The following is a description of a gene set: from publication Yevshin I, Sharipov R, Kolmykov S, Kondrakhin Y, Kolpakov F (PMID 30445619) Genes containing one or more binding sites for (Taf10) in their promoter regions (TSS -1000,+100 bp) as identified by GTRD version 20.06 ChIP-seq harmonization. species: Mus musculus Mouse Gene Set: TAF10_TARGET_GENES, and this is the list of marker genes: Kmt2d, H2ac14-ps, 2700062C07Rik, Itga2b, Ngp, Trim80, Il21r, Sucnr1, Aoah, Fermt3 (fermitin family member 3), Itgb5, Mrpl44, 1700122E12Rik, Ski, Piezo1, Atg14, Madd, Ndufa5, Ankrd13a, Cdc123, Hs2st1, Ece2, Cebpz, Snord49a, Tchp, Ptgs2os2, Lig1, Taf11, Oit3, Rbm47, Ppp1r15b, Epb41l4aos, Alkbh2, Med6, Cfap126, Trappc3l, Zfp276, Mrpl22, Mirt1 (NCBI Gene Id 78096), Misfa, Gpld1, Trabd, Ncor1, Ppil1, Lss, Gbp11, Rbak, Klhl20, Cir1 (NCBI Gene Id 74817), Anp32e, Sgsm1, Fdps, Secisbp2, C920006O11Rik, Rab21, Dhodh, Mrpl39, Lyrm1, Trmo, Sec24a, Syne2, H2ac4 (H2A clustered histone 4), Tifab, Gpr107, Cd274, Hmga1, Osbpl6, Klhdc4, Gm13421, Taf13, Gclm, Dhx38, Vsir, 4930532M18Rik, Hoxa7, Abca13, Txnl1, Polr1f, Hepacam2, Rps12, Cenpw, Lsm8, Rpl18, Ubr4, Lrrc24, Tspan32, Brix1, Cep57l1, Slc39a14, Rin2, Mmp8 (matrix metallopeptidase 8), Psmg3, H2ac15, Ccng1, 1810024B03Rik, Rab11a, Gm15564, Polr1b, H2ac22, Ncbp2as2, Gm12279, H3c3, Isg20, Tm9sf4, Ctnnb1, Triobp, 2310010J17Rik, Dip2a, Fam43a, Gm8000, Naa25, Tm9sf1, Utp14b (UTP14B small subunit processome component), Nbeal2, Mapkapk3, Mrpl21, Plek, Polg2, Sla, Git2, Cd53, Pex1, Glrx3, Dus2, Gtf3c5, Psap, Prkag2, Lyar, Elk3, 6030442K20Rik, Pten, Grcc10, Fam222b, H2bc4, H2ac20, Gm26802, D330023K18Rik, H3c10, Fut8, Abcd2, H2bc6, Gpatch3, Arhgef7, Gm11335, Ppp1r18, Diaph2, Cebpa, Dennd4b, Dus1l, Ptprv, AI467606, Gm807, Pparg, Bbof1, 2610005L07Rik, Vps51 (VPS51 GARP complex subunit), Mrpl30, Pigb, Snord118, Eif3a, Tomm22, H2ac7, 4933406C10Rik (RIKEN cDNA 4933406C10 gene), Lrrk1, Yipf2, Rsrp1, Rnf169, Cyp51, Hps6, H2bc21, P2rx3, Gm15133, Ifrd1, Spns1, Cdk2, Plekha2, Sphk2, Dhrs7b, Selenof, Cdkal1, Ubtf, Ighj2, Cdkl4, Ptpre, B2m, Lratd2, Rad54l2, Prtn3, Zbtb9, Mcpt8, Mir5122, Eldr, Mrpl52, Gtf2b, Ndufa12, Tecpr1, Snord49b, Id1, Gm11292, Opa1, Psmd3, Abraxas1, H1f4, Rhob, Nosip, Serping1, 6720482G16Rik (RIKEN cDNA 6720482G16 gene), Gpat3, Slc16a6, Gm10699, Sp3, Alas1, Fbxl4, Csnk1g3, Nsun5, 0610030E20Rik, Frat2, Upf3a, Tbc1d9b, H2ac5-ps, Mttp (microsomal triglyceride transfer protein), Col15a1, Mmp19, Dock8, Ddc, H3c11, Tsen15, Gm15706, Epn1, H3c14, Pcyt2, Cxcr3, Bclaf1, Slc15a4, Tma16, Lrrc8d, H3c15, Rad1, S100a2, Tnfrsf14, Foxred2, H2bc12, Alg3, Eif2a, Igf2bp3, Slc28a2, Cpsf1, Tnfsf14, Prdx1, Erp27, Nop16, Amdhd2, Kbtbd4, Pcid2, Patz1, Serpinf1, Gm40332, H2ac18, Fos, Hes6, Tars2, Knl1, H1f3, Polr3a, Trub2, Sfswap, Nampt, Psen2, Commd2, Gm16537, Edc4, P2rx1, 1700017B05Rik, Eme2, Anxa2, Ptk2, F830208F22Rik, Rbbp5, 9430069I07Rik, Pik3c2g (phosphatidylinositol-4-phosphate 3-kinase catalytic subunit type 2 gamma), Wdr36, 4930519P11Rik, Dgat1, Stfa1, Tapbp, Ly6c2, Gm23143, 0610040B10Rik, Rpl14, Icam2, Grn, Bbc3, Gas2, Ak2, Slc39a3, Calr, Triap1, Thbs4, Krcc1, Cd69, Gucd1, Tmem134, Trappc11, Sema4a, Rasa1, Ints6, Eif3g, Wtap, Gm20186, Ctdsp1, Cnbp, Cdca7, Mideas, Wdfy1 (NCBI Gene Id 73607), Cops8, Dcakd, Cfap298, 2900005J15Rik, Unc5a, Cd44, Atg101, Ulk2, Odad1, Mir6236, Ppp1cc, Tsc22d2, Elmo1, 4930509E16Rik, Setd1b, Rnpep, Mir8112, Cltc, Tatdn3, Arhgdia, H2bc22, Scamp3, Stard6, Rnf11, Fam110a (NCBI Gene Id 99062), Snrnp27 (NCBI Gene Id 66618), 4930452N14Rik, H1f5, Chdh, Vps37a, Ifngr1, Brf2, Gtf2a2, Rpl10, Kcnq3, Dnajc10, H3c6, Acsl3, Tefm, Ikzf1, Gls, Gm12967 (predicted gene 12967), Eif4a1, Sos2 (SOS Ras/Rho guanine nucleotide exchange factor 2), Cfp, Arrdc3, Acsf3, Mrpl3, Sesn1, Eri1, Spp1, Ppp2r5e, Raly (NCBI Gene Id 99057), Btnl9, Casp8, Snrpd3, Tax1bp1, Picalm, Thap6 (NCBI Gene Id 75186), Adcy7, Ccny, Sec22c, Kifc1, Asb15, Gm16531, Fbxw8, Gm19331, Ncbp2, Endou, Snrnp200, Ndufa9, Pex3 (peroxisomal biogenesis factor 3), Tal1, Gpr155, Ighg2b, Agk, H2ac8, Vps50, Mrps31, Ppt1, Cep104, Rsbn1, Ggt1, Vps9d1, Gas7, Atp1a3, Evi5, Hspa9, Ndufa7, Naaa, Nop56, H2ac12, Ewsr1, Ptges, Zbtb14 (zinc finger and BTB domain containing 14), Copg1, Eif2b5, Hus1, Sgip1, Mrpl58, Slc11a1, Wnt10b, Gatc, Pgm2, Hoxa9, Dock10, Rbpj, H2ac11, H3c7, Pigbos1, Bud13, Nuggc, Camkk2, Psmc1, H1f1, Zkscan8, Isca1, Papln, Bms1, Ube2j2, Blvra, Ccdc88a, Apbb1ip, Supt7l, Kmt2a, Sumf1, Wdr70, Rasgrp2, Nfkb2, Hhex, Ift57, Cst3, Glipr1, Ano7, Coq4, 4930558J22Rik, Zdhhc4, Dhx16, H2bc7, Rdh14, Mrps34, Odf2l, Gm11475, Ttc4, Mtmr9, Gpr141, Exosc4, Mitd1, Smarcd2, Zc3hc1, Kctd5, Ankrd40, Pdcd4, Dmap1, Scrt1, Cnot7, Chmp2a, Ro60, Dapp1, Rpl36, Neurl3, Zc3h12a, Gm7158, Trp53rkb, Ighmbp2, Gm16116, Tfeb, 1810021B22Rik, Fyco1, 2310001H17Rik, B4galt7, Mgrn1, Hgsnat, Clec12a, Mylk, Dcp1a, Scarna2, Ints14, Fastkd5, 4933406P04Rik, Coq2, Poldip3, Dpy19l4 (NCBI Gene Id 93698, dpy-19 like 4), Rfx7 (regulatory factor X, 7), Adrm1, Pigl, Prdm11, Mtg1 (NCBI Gene Id 212508), 3110031N09Rik (NCBI Gene Id 73141), Rplp1, Slc2a3, Cox14, Rpl37, Arid1a, Rbsn, Cwc27, Tial1, Rps2, Top2a, Gm11346, H4c3 (H4 clustered histone 3), Gm27252, Pigq, Pgk1, Slc8b1, Rad23a, Ndufs7, Rfx5, H2bc18, Aaas, Dapk3, Neat1 (nuclear paraspeckle assembly transcript 1 (non-protein coding)), Zbtb49, Rpl26, Trbv1, Gfm2, Tspoap1, Arfip1, Ccnd3, 4932441J04Rik, Dusp12, Rarg, Ccnc, Lmo7, H2ac6, Cx3cr1, Fech, Stx16, Smad3, Mir142hg, Polr2m, Ighj1, Hes1, Smg6, Aip, Mcee, Dmwd, Ptma, Irag2, Rbks, Dab2ip, 5730455P16Rik, Cops7b, Slc15a3, Adra1a, Casp3, Rcor1, Gm12439, Atp1b1, Ndufaf1, Polg, Lemd2, Parg, Slc45a4, E2f8, Ube2e2, Rps11, Gm17138, 4930509H03Rik, Fam149b, Aff1, Ptpn7, Sdf2l1, Haus5, Krr1, Acbd5, Mettl17, 1810008I18Rik, Cox15, A430072P03Rik, Eif5b, H4c8, Ncam1, Rnf149, Frg1, 6330549D23Rik, H2bc8, Syf2, Dnlz, 2410006H16Rik, Adnp, Ncf1, Slc26a11, Ndufs3, Scrib, Ighg2c, Rbm48, Smg8, Srek1ip1, Abcb8, Dbi (diazepam binding inhibitor), Slc27a2, Rdm1, Wdr5, Ist1, Wdr48, Niban2, Rbm8a, Galnt3, Txndc9, Rars1, Trmt10a, Klhl23, Ppp6r3, Rhbdd3, H2-Q4, Lzic, Uchl5, B230208H11Rik, Rnf123, Ttc5, Dnajb14, Dffb, Alkbh3, Tob2, Tdrd3, Cytip, Mbd3, Tmem242, Guf1, Cd68, Il16, Gm13562, Nsa2 (NSA2 ribosome biogenesis homolog), Slc4a1ap, Ap2b1, Frmd8os, Junb, Kdm5b, H4c1, Zfp740, Gm19280, H4c2 (NCBI Gene Id 326620), Lrig2, H2bc15, Rnf151, Polm, Rrp36, Ighd4-1, Cdk5rap1 (CDK5 regulatory subunit associated protein 1), Wdr18, Ercc6l, Qser1, Iqce, Msh6, Ccdc77, Esyt2 (extended synaptotagmin-like protein 2), Gm11398, Ccdc107, Il6ra, Cstf2t, Ssb, Card6, Sema4d, Runx1, Gm15320, Mctp1, Flot1, Mrps18c, Zfp91, Frs3, Bcl2, Lrrc40 (leucine rich repeat containing 40), Mynn, Nmt1, Rhobtb1, Ankle2, Timm23, Lhx1, H1f2, Xkr8, Pmel, Ralgds, Cul4a, Gm11471, Gfi1, Mnat1 (NCBI Gene Id 320958), Hcar2, AI480526, Tex14, 4930456G14Rik, Tnpo1, Recql5, Gm2449, Taf6l, Rab26, Tex2, Rgs18, Aurkaip1, Fnta, Ppia, H2bc11, Rbm34, Gm28809, Sfr1, Prkag1, Helq, Sap30bp, Hnrnpa0, Trip4, Bbs1, Cfap54, Or10aa1, Nras, Gm19261, Lamtor5, Nmnat1, Ttc39d, H3c1 (H3 clustered histone 1), Angpt1, Fdx2, Styk1, Tyrobp, Dele1, Nol10, Ubox5, Plpp1, Rps28, Rgl2, 4933440N22Rik, Hp, Rpe, Slc38a2, Gm15581, Tle4, Mrpl1, Dhrs11, Tmem30a, Adam17, Usp28, H4c18, Slc37a3, Apoc2, Nfil3, Ndufc2, Stx18, Tbpl1, Ecd, Klhl3, Mphosph10, Skp1, Trap1 (TNF receptor-associated protein 1), Idi1, Rassf2, Fkbp15 (FK506 binding protein 15), Mafg, Pop4, H2ac13, Dhrs9, Zfp236, H4c9, Slc9a1, H4c11, H2-Q7, Taco1 (NCBI Gene Id 70207), Rwdd4a (RWD domain containing 4A), Dclre1c, Synpo, Tnf, Pygo2, Anp32a, Ankrd13c, Sypl1, Rbm38, Tmsb4x, Alyref2, Fbxw2, Bcr, BC005537, Tle1, Insr, S100a8, Plgrkt, Irf2bp2, Ctbp2, Erich1, Mknk2, Fam8a1, Txnl4b, Zfp560, Gm25541, Ndufaf7 (NCBI Gene Id 73694), Cep192, Smn1, Atp8a1, Taf12, Arap1, 4930429F24Rik, Chchd2 (coiled-coil-helix-coiled-coil-helix domain containing 2), Arhgap35, Mcm3ap, Sar1b, Ddx55, a (nonagouti), 1700029M03Rik, Adcy10, Spdye4b, Mir223hg, C130050O18Rik, Serp1, Sucla2, Dhx30, Gm14052, H2bc3, Asph, Rabggta, Gm23639, D230022J07Rik, 4930503L19Rik, Ublcp1, Angptl8, Tomm6, Nek9, Mrpl48, Pvt1, Tent5a (terminal nucleotidyltransferase 5A), H2bc13, Ggnbp1, Calm1 (calmodulin 1), P2ry6, Ufsp1, Eapp, Rapsn, Kdm5a, Tmem229b, Gm11999, Itgb7, Tsbp1 (testis expressed basic protein 1), Gm22513, Hal, Prrg2, Gm40190, Dnmt3l, Pcdh7, Mcph1, Hnrnpc, Etohd2, Kdm5c, H3c8, Kras, Srsf7, Kmt5b, Zc3h10, Ncoa4, 4930502E09Rik, Pfn1, H2ax, Nsl1, Ubb, Frmd4a, Tti2, C630043F03Rik, Lmnb1, Gtf2a1, Bola1, Tbata (NCBI Gene Id 76570)